Given this list of marker genes Sphk1, Ptgis, Ptgs2, Ptges, Ptgds, Sco1, Ptges2, Ptges3, Cthrc1, Ptgs1, here is a description of the gene set: Mouse Gene Set: GOBP_CYCLOOXYGENASE_PATHWAY The chemical reactions and pathways by which prostaglandins are formed from arachidonic acid, and in which prostaglandin-endoperoxide synthase (cyclooxygenase) catalyzes the committed step in the conversion of arachidonic acid to the prostaglandin-endoperoxides PGG2 and PGH2. species: Mus musculus